Given this list of marker genes ANXA2P2, SNCB, ANXA8, PDC, PLA2R1, SCGB1A1, ANXA5, APOC1, ANXA4, ANGPTL3, ANXA2, ANXA1, SNCA, ANXA3, PINLYP, here is a description of the gene set: Human Gene Set: GOMF_PHOSPHOLIPASE_INHIBITOR_ACTIVITY Binds to and stops, prevents or reduces the activity of a phospholipase, an enzyme that catalyzes of the hydrolysis of a phospholipid. species: Homo sapiens